The following is a description of a gene set: from publication Yevshin I, Sharipov R, Kolmykov S, Kondrakhin Y, Kolpakov F (PMID 30445619) studied in species Homo sapiens Human Gene Set: HMGA1_TARGET_GENES Genes containing one or more binding sites for (HMGA1) in their promoter regions (TSS -1000,+100 bp) as identified by GTRD version 20.06 ChIP-seq harmonization., and this is the list of marker genes: HSD17B12, PDCL3P3, KRT8P6, PDLIM5, RN7SKP170, ADH1B, RNU4-26P, OR4A2P, CCNB3, RBX1P1, ENSG00000197320, ARHGEF28, ACTG1P15, PCDHGA11, ANKRD33BP6, RN7SL825P, SLC25A14P1, ATM, COPS3, RNU6-57P, RNU6-544P, USP3, CRHBP, RNU6-674P, RN7SKP257, CCSER1, LRRIQ1, MTRR, MLIP, ERICH6, TLE2 (TLE family member 2, transcriptional corepressor), USP39 (ubiquitin specific peptidase 39), AGPAT5, ACVR1C (NCBI Gene Id 130399), MYCBPAP, PIWIL2, SNORA16B, MON2, INTS3, RPL34P19, MTMR12, GAL3ST1, RPL7AP2, PRDX3P4, TRPA1, MED6, PRKN, PLA2G12A, LINC02881, HPN, DENND2B, E2F5, SMARCA2, DCLRE1C, LRRFIP1P1, RNU6-607P, DNAJC17P1, PCDHA2, LINC01035, SMCO4P1, GUCY2D, DDX46 (NCBI Gene Id 9879), RN7SL332P (RNA, 7SL, cytoplasmic 332, pseudogene), DNAJB14, COL21A1, ATP1B3, PPP1R2, OR9G3P, RN7SL131P, DNM1P38, MIR4471, ASNSP4, LINC02806, RPL37A, SNORA71, RNU6-308P, SCP2D1-AS1, NRXN3, CCDC172, OPA1, IMPA1, RN7SL542P, ID4, NPHP3, THADA, ETF1P3, UBE4B, CPD, FOXR1, ECD, MIR7156, HACE1, PAIP1, FUNDC2P1, ANO10, RNF32, TRDN-AS1, TPT1-AS1, ASAH1, FOXD3-AS1 (FOXD3 antisense RNA 1), HCG24, H3P37, RNU6-1284P, TSHZ2, RPL17P23, NT5C2 (NCBI Gene Id 22978), CLUH, CYP2C8, TEX41, RAPGEF1, EPB41, TP53BP2, CCDC73 (coiled-coil domain containing 73), RNU6-1180P, ENSG00000213963, ABCA10, DCUN1D2, NETO1, RNA5SP360, C7orf78, ENPP3, SLC25A36, DPYD-AS1, SIRLNT, FAM227B, RNF213, ARSD, PLCL1, UBE2E2 (NCBI Gene Id 7325), FAM3C2P, CACNB2, LINC01640, CRLS1 (cardiolipin synthase 1), ANKRD33BP10, SPECC1L, CCDC102B, MXRA7P1, AMY2B, GAPDHP43, BRWD1, IGF2BP2, SANBR, FRMD3, MROH9, CEP41, TMEM50A, EGLN3, SEC63, ZNF536, OMA1, LINC02615 (long intergenic non-protein coding RNA 2615), RPL21P32, LINC01739, TPR, RRM2B, CDK17, GLT8D2, IQCF1, SMSP1, RNA5SP30, XPO1, ASIC5, RNF212B, CALCOCO2, LAMA4, PICSAR, MTERF3, LINC03000, RPL21P59, USP6NL (USP6 N-terminal like), FOCAD, CCDC88A, SNORA12, IL15, BSDC1, PHF8, CD163L1, NF1, MYBPC3, LSM14A, IL6ST, TMEM40, RNF32-DT, ADGRF5P1, DEFB134, FCHSD2, RPL13AP22, FRYL, LINC00446, STIL, HBG2, OR4G3P, IKBKB-DT, RNU7-130P, TIAM2, CPNE4, ATP5MGP8, RAB3GAP2, LINC01229, CCNB1IP1 (NCBI Gene Id 57820), ZNF99, SCN7A, EYA4, USP34, IFT57P1, ST7, SCUBE2, TXNP7, RSAD1 (radical S-adenosyl methionine domain containing 1), OR2T32P, PCYOX1, SLC12A2, EIF3J, GSTP1, N4BP2L2, STEAP2, XRN1, DYNC2LI1, LINC02428, AFG3L2, RFKP2, RRM2P2, DIP2B (disco interacting protein 2 homolog B), LINC02018, TSPAN8, P3H2 (NCBI Gene Id 55214), VN1R65P, MCEE, RAI1, KRT18P44, TRMT112P1, NDUFB8P1, ELL2, CCBE1, ZNF880, ITGB3BP, AHCYL2, RNU6-587P, NRG1-IT3, SLC22A9 (solute carrier family 22 member 9), GAPT, OR8R1P, MON1B, KIF27, HNRNPA1P7, NOL6, ENTPD4, ENSG00000250378, MYO1E, ARHGAP10, KMT2E, SORBS2, RUBCNL, SETDB2, MT-TR, DYNLT5, LINC01905, SEPHS1P1, ITIH5, ATP5PFP3, CRIPTOP4, LINC02922, MIR1537, TCEAL1 (transcription elongation factor A like 1), RALGAPA1 (NCBI Gene Id 387984), MRPS35, LYZ, OR2B8P, HLA-DPA3, A2M, EZH1 (NCBI Gene Id 2145), ACAD10 (NCBI Gene Id 80724), SPAM1, KDM5A, AHSA2P, TAAR8, BRCA1, MIRLET7C, SMG8, DMXL2, CPS1-IT1, TRAJ13, UGT2B10, KRT18P2, CDC16, TPTE2, RPGRIP1L, RNA5SP342, VN2R3P, CDK1, SLC14A1, MTCO3P15, LINC01899, LINC02715, SMURF2, DAZAP1, NFE2L2, HTR3A, SLC25A16, MTND1P35 (NCBI Gene Id 106480433), ZFAND3, PGR-AS1, CFTR, ARF1P1, RNF13, RPS3AP6, PEX12P1 (peroxisomal biogenesis factor 12 pseudogene 1), CHN1, TRIM53CP, GLRX3, HNRNPA1P1, HNRNPA1P58, PDK4, KCTD3, RNA5SP491, LIFR, CASK-AS1, VIRMA, THOC1, AIDA, HBD, FOXK2, MIR3650, SCTR-AS1, SPTAN1, RFX2, BIRC8, TRAV29DV5, SPAG6, PFN1P2, CDKN2A-AS1, RN7SKP188, SDHC, LINC02429, VPS35, ZNF731P, LINC01103 (long intergenic non-protein coding RNA 1103), MTND4P17, ABCB5, OR6K5P, WDR41, UBE2D3P2, TFDP2, BET1, RNU6ATAC26P, ZNF317, PCBP1-AS1, MIA2, LRRC52-AS1, FARP2, RNU4-12P, TRIM31, IGHV1OR21-1, KLK14, IGHV3-62, USP45, ANXA10, CLUL1, GNS, ZNF732, UNC5D, LINC01781, CD36, N4BP1, KCNK1, EHMT1, AIG1, ZNG1E, APBA3, LPIN2, LINC02770, LINC01102, COG3, SGK1, SORT1, OOSP2, ZNF729, RPS6KA5 (NCBI Gene Id 9252), CXXC1, CYCSP4, CLEC2B, RBMS3 (NCBI Gene Id 27303), ESF1, MSR1, MTHFD2P4, VN1R67P, NFIB, INO80, NVL, PTPN5, RNU6-812P, CTTNBP2, TRHDE, WDR7 (NCBI Gene Id 23335), NXPH1, RASGRF2, OR4L1, WDFY2, RNU6-1271P, CNN2P9, SAMHD1, JAK1, RPL35AP29, LRRC51, STUB1P1, SLC25A5P5, MRPS30, RN7SKP246 (RN7SK pseudogene 246), KMT5AP3, NFAT5, RNF19A, CLDN16, REPIN1, GCSHP4, LINC01588 (long intergenic non-protein coding RNA 1588), ACOXL, DPY19L1, STAT1, ADD3, DUS4L, CASC6, ANGPTL6, TAS2R15P, GABRA6, HMGB1P46, NKTR, BNIP1, TNFRSF25, UGT2B11, DSCR4-IT1, COQ3, RAB39B (NCBI Gene Id 7489), FAM98B, RPL23AP44, MBD1, ENSG00000251545, STIP1P3 (stress induced phosphoprotein 1 pseudogene 3), ACIN1, DNAH3, MT-TP, ASS1P5, PRPF39, ANKRD13C, RNF128, EMBP1, STAG2, EFCAB13, TNIK, RNU6-925P, DICER1, RPL21P53, MIR4300HG, WAC, COL6A3, SNORD65B (small nucleolar RNA, C/D box 65B), SPECC1L-ADORA2A, GOLGA2P6, RUFY2 (RUN and FYVE domain containing 2), FABP2, RNU6-790P, LRCH3, CCDC18-AS1, LINC02766, RN7SL296P, LINC02605, CLVS1 (clavesin 1), KCNMA1, HPS1 (NCBI Gene Id 3257), NPM1P21, CCDST, ZBED2, ST7L, NAA15, SCN2A, RN7SL580P, STIM2, MICU2, SNORD123, OR2B2, RPL12P9, TASOR2, RNU1-45P, RN7SL804P (RNA, 7SL, cytoplasmic 804, pseudogene), PARP16, C1RL-AS1, THG1L, ANKUB1, DIS3L, LINC02613, MIR548H3, C1orf167, CS, ZFP30 (ZFP30 zinc finger protein), RTN4, LINC01381, RPS4XP9, TRAV9-1, PDE4DIPP6 (NCBI Gene Id 647500), RNU11-5P, MBIP, ELK4, FMN1, VAV3, SPIN2B, ARHGAP12, MAGEC3, AMD1, OR5BN1P, CCDC144NL-AS1, TBC1D32, ITPRID2, LINC01320, TMEM225B, RPS15AP20, NCAPD3, MTCYBP36 (NCBI Gene Id 109729116), CATSPER2P2, DYNLT3, LINC02479, RPS27AP8, IFT80, TMEM263, LINC01028, C8B, EIF3LP2, POLR2MP1, R3HDM1, HLA-E, IARS1, PTPRK, CPSF3, C20orf173, RNU6-901P (NCBI Gene Id 106479965), PPP1R12B, CDKN2B, FOXJ3, NT5DC1, RFLNB, GFPT1, RTCA, ZPR1P1, PPP2CB, RN7SL520P, RN7SKP160, ANKRD20A11P, IFITM3, SPRY4-AS1, NFATC1, SLMAP, PCDHB12, UBE2G2, ABI2, PLEKHM1, RNU4-54P, ZDHHC20, RN7SL384P, CTPS1, RNU6-984P, SSU72P1, ENSG00000212279, RFTN1, SON, KCNAB1, RPL37P15, RGS12, DDX18, ECT2, ZNF280D, DMAC2L, ANAPC1P6, RNU6-602P, CENPF, ANKRD7, ACBD7, CFLAR, CCDC66, ASH1L-IT1, MIR548AR, SYNE1, MOK, LANCL2, NAP1L4P1, GLYAT, KIDINS220, GRAMD1B, GATA4, ATG2B, JAM2 (NCBI Gene Id 58494), RPS10P29, TAS2R42, STRAP, RNU6-275P, KRTAP4-5, MIR4422HG, ENSG00000274458, GALK2, EEF1DP8, PTPN13, SNORA74C-1, DAG1, ITM2B, RNU4-50P, NUBPL, PABPC3, RPS27AP20, LIM2-AS1 (NCBI Gene Id 105372446), KRT18P8, RAD51B, RBKS, RNA5SP166, KNTC1, RAB6C, SLC2A9, QRICH1, ZNF737, SRR, SACS-AS1 (NCBI Gene Id 100507742), RNF135, BCAS3, LINC00343 (NCBI Gene Id 144920), KPNA3, EXOSC9, SCAF11, VN1R5, RNU6-583P, FYTTD1, CLHC1, RFPL4AP5, OR5H5P, MARK2P4, CRAT37, OR4C10P, NCOR1, BANF1P4, VWA8-AS1, MIR1915HG, RN7SL93P, PGBD4P8, UQCC6, HIGD1AP18, RNU6-982P, CDK2AP2P2, CLEC2D, CLINT1, LINC02566, SNW1, ARID4B, SLC4A5, HNRNPMP2, COPS2, ZNF638, TARID, MTPN, RPL7L1P4, GPC2, CMYA5, KRT19P1, ADAM9, TASOR, GOT2P3, PIPSL, RN7SL44P, TCEAL8P1, NEGR1, PCGF1, SEMA6B, MIR7154, RASAL1, DNAJC2, MEGF10, MIR2113, MIR4529, ICOS, CFAP221, ZC3H7A, ADAM3A, ADGRE4P, SEPTIN10P1, RNY3P13, ADAD1P1, RHOBTB3, RNU6-1135P, OR2AD1P, FEZ2, PIGC, LRIG3, ZPLD2P, MAP4K3 (NCBI Gene Id 8491), RPSAP61, ITGA3, SFTA1P, ZFAND2B, NPHP3-ACAD11, CD84P1, ZNF224, SFT2D1, RAB11FIP2, ENSG00000212626, SUMO2P5, USP2, RN7SKP58, GSTM2, MAP9-AS1, ZC3H14, LBR, RPLP0P7, ILDR1, RPL19P7, ALLC, CEP76, HNRNPA1P37, RNU5F-7P, HECTD4, TP63, SPAG9 (NCBI Gene Id 9043), LINC02114, RNU6-468P, PIGF, ZNF101P1, TENM3-AS1, MIS18A-AS1, TLR7, HDAC9, GABRB3, ENSG00000259737, PSME4, CCDC82, RPL21P132, DCUN1D4, OR52U1P, CA5A, LINC02006, KLRA1P, EMSY, LAMTOR5-AS1, IGHV3-48, URI1, LINC02942, RNU1-83P, PSMC1P10, EBF1, FAM200B, NRIR, YTHDF2P1, KSR1, MKRN2OS, CBFA2T2, MARK3, DNAJB13, RNU6-1036P, GYS2, SCN8A, MSL3P3, LINC01517, MIR6806, CORIN, NFXL1, SETP21, NANOGNBP3, CT75, ANK3, RPEP1, LMO3, TRIM54, FRG2DP, CKS1BP1, KRTAP4-1, TMPRSS11A, RNU6-677P, RNU2-45P, COX5BP3, AKR1C1, LIPN, RPL7L1P14, TBC1D1, PDE11A, ROCK2, KRT8P11, PPP2R5C, AOX1, PXK, RNU6-590P, RPL7P15, SALL4P6, GLS, ZKSCAN8P1, BMX, SNORA20B, OR2AJ1, SRGAP1, SLC38A9, CLK1, LIFR-AS1, DEPDC1, NUCB2, C2CD5, TMEM144, EIF4A1P6, ANKRD33, RNU5E-3P, MMP2, LINC01602, GIT2, RNU6-635P, OR8J2 (olfactory receptor family 8 subfamily J member 2 (gene/pseudogene)), TPRXL, RPL19P5, LIVAR, DDTP1, ILRUNP1, CHMP7, THOC2, NDUFB7, PDE5A, KCNAB1-AS1, PSMC3P1, ADGRL3, PAPOLA, NAV2-AS3, ENSG00000258702, RPL30, PARP14, SMYD3, RAB31, ADGRF5, MTATP6P18, RN7SL581P, NRAD1, TNNI3K, IFI44L, COBLL1, PRSS12, CCPG1, HSD17B7P1, RNU4-4P, LINC02790, PLS3, CLNK, SPIDR (scaffold protein involved in DNA repair), CEP97, PATJ, LINC00929, NCOA4P3, GPHN, DDX60L, RANBP17, PRR5L, AP2B1, SLCO1B3, TNKS, WTAPP1, RNA5SP297, FAM184A, ENSG00000279134, CCL28, ANAPC5, CBLN2, CD38, SLC18B1, MIR3691, UMLILO, ODF1, CAPS2, UBAP1L, AKAP17A, MIR4685, TAS2R19, MRGPRX9P, NOTCH2, FSBP, WDR19, SUZ12P1, CSN1S1, DIRAS2, MACF1, SRSF5 (serine and arginine rich splicing factor 5), OR8I1P, PRPSAP2, TRIM60, FAM230G, BBX (BBX high mobility group box domain containing), ARPC3P3, ZNG1A, CTSD, AKR1C5P, ACACB, MRPL48, VBP1, PCNX1, E2F3-IT1, OR10AB1P, ENSG00000282904 (NCBI Gene Id 107986277), EHBP1, EFCAB8, EML6, RNU6-1111P, CFAP44, LINC01182, HEXB, UCHL3, LEF1, SERPINB11, SMCHD1, LINC01088, DYNC2I1, AP4S1, LYPD1, RNA5SP396, GPRIN3, MEP1AP1, ASS1P3, TNFRSF19, USP7, RPL6P11, FOXP2, PDS5A, PLOD2, HHLA2, SCOC, SIPA1L1, EFCAB2, PEX5, OR6C72P, RNU6-1136P (NCBI Gene Id 106480066), DPYS, MTPAP, TFEC, MIR455, LINC01888, ENSG00000212415, PERPP1, RPS27AP11, PPIAP17, PHF5AP3, SLC14A2-AS1, LYST, G6PC2, DIMT1, RNU6-987P, CFH, KLKB1, ANKRD33BP2, CCDC138, TMEM62, BPTF, ATG4A, LRP5, LINC01147, MZT1P1, LINC02455, LPCAT2, ARHGEF11, HUS1, EXT2 (NCBI Gene Id 2132), IREB2, ZDHHC2, PTPRT, ATP1B3P1, MT-ND4 (mitochondrially encoded NADH:ubiquinone oxidoreductase core subunit 4), BLTP1, HDDC2, DHRS9, MEIS2, LINC00682, RN7SL538P, SPTLC1, TUBBP6, LAMB4, SILC1, GALNT16, RYR3, MARK2P5, MALT1, TRAV28, RPL35AP4, PPFIA1, ASPH, UTP15, KLF12, A2MP1, KRT8P2, RNA5SP153, AMER2, SF3B3, CCDC158, ZNF208, SEC23A, ARSL, CRNDE, LINC02527, TTC39C, AGK, SYNPO2, TFAP2A-AS1, PLAGL1 (PLAG1 like zinc finger 1), FAM182B, DPRXP4, ANXA2, APC, LINC01680, FAM21EP, OR7D2, CDKL1, LINC02978, CD55, MUC20-OT1, IL4R, CABYR, NUMB, FAM229A, RPL17P24, ENSG00000206987, IGKV2-18, GLRX2 (glutaredoxin 2), RUFY3, LINC01592, YBX3, LRRC37A3, ITGB7, ZNF561, CAPZA1, ZMYND11 (zinc finger MYND-type containing 11), PARD3B, IMPDH1P9, RIOK3, ACSL3, EFCAB3P1, UBR5, PRRG1, BUD31, PIAS2, PPA1, CNTNAP3, GPR158, PLA2G4C-AS1, IGF2R, CALHM4, ESR2, NKX3-2, DOCK7, ZNF124, HMGN1P1, KRTAP22-2, RGS1, CHRM3, MTCO3P8, OSGEP, RN7SL479P, SPATA16, RNU6-439P, NFATC3, RNA5SP465, PLCB1, RNU6-945P, RIOK2, MIR3929, VN1R90P, HLA-DOA, ACADL, NAB1, ATF7IP2, DDX55, SRP14P1, ANKRD44, RPL31P12, BORCS7-ASMT, AHI1, CCDC178, MRPL54, RFWD3, IGHV3-50, CRB1, ATP9B, RNU6-500P (RNA, U6 small nuclear 500, pseudogene), SH3YL1, HERC3, VSTM1, PFN1P4, CHRM5, DOP1B, ENSG00000241345, CNOT1, SPATA4, OR14L1 (NCBI Gene Id 81454), ZNF675, H3P10, WFDC8, UBE2U, PCDH9-AS1, SETP15, SETP16, HERPUD1, FMN2P1, RGS21, DAB1-AS1, PNP, NFKBIZ, HSPBAP1, RPL12P34 (ribosomal protein L12 pseudogene 34), MIR4795, TXNP6, RHPN2P1, KNL1, ABCA4, PKIA, ASCC3, ISCA1P3, ITGAV, IL18, POP4, TRPM7, NUB1, CFAP61, HOOK1 (hook microtubule tethering protein 1), PIBF1, ENSG00000187951, AKAP9, GLRA2, PPIAP7, MIR3672, LINC02330, ENSG00000273507, RILPL1, ARFGEF1, SLC44A3-AS1, MIR4477A, ZEB2, FTO, RNGTTP1, PWRN1, RPEP5, CNKSR2, CNN3, EPB41L5, USP14, IGF2, SIDT1-AS1, NCEH1, ACTG1P13, TMEM132D, LINC02721, KCTD4, GTF3C1, RNU6-150P (RNA, U6 small nuclear 150, pseudogene), ETFB, JPT2, RNU6-386P, PFN1P3, CAPN7, UBD, SBF2, IGHV3-76, SPG11, STAG3L5P, CNTN1, RBM44, MRPL40P1, RNU6ATAC41P, CROT, BPNT1, SLC6A16, RNU6-534P, RNU6-30P, LDHB, B3GNT6, DDX5, MIR99A, ZNF84, SHPRH (SNF2 histone linker PHD RING helicase), BMP2, PDZRN3, LINC00559, MRPL36P1, SRPRB, ZNF781, ROCK1P1, PRR27, PIK3CB, RNU6-680P, FOXB1, CPNE8, SELENOTP1, ANGPTL1, RANP1, RNU7-151P, SYTL1, BOLA1, FAM240B, NIPA1, CNTNAP3B, FBXO9, HMGB1P13, ZNF554, MTFR1L, PIEZO2, ANXA5, GRK4, RPL21P74 (NCBI Gene Id 100271184), CRIP1P2, ATP6V0A4, LDLR, SDCCAG8, PDGFRA, OAZ1P1 (NCBI Gene Id 728602), CYP1B1-AS1, HSPA8P8, RN7SL98P, COX7CP4, INTS8, ARHGAP15, ENSG00000283666, INPP5D, C1DP2, ABT1, LINC01798, MT-ND4L, UBR1 (NCBI Gene Id 64703), TMEM161B, OR10D5P, MFSD1P1, GLTPP1, HNRNPLL, CAMKMT, SEPTIN7P14, COL11A2P1, XBP1, ZNF592, C8orf34, WFDC10A, PRIMPOL, FTH1P2, NICN2P, TRO, UMODL1, KCTD2, RGS9, CPB1, PCDHB1, OR5H3P, CYB5R2, ERI1, SLC8A1-AS1, RNU6-911P, MIR4450, RNA5SP361, ANKRD46, IP6K2, BORCS7, LINC02571, SMARCAL1-AS1, PDE4D, B3GALNT2 (NCBI Gene Id 148789), LINC02190, RPL21P46, CASC8, TAAR1, CYLD, OR5AK3P, RNU6-136P, RNU6-968P